The following is a description of a gene set: Human Gene Set: GOBP_CEREBRAL_CORTEX_GABAERGIC_INTERNEURON_DEVELOPMENT studied in species Homo sapiens The process whose specific outcome is the progression of a cerebral cortex GABAergic interneuron over time, from initial commitment to its fate, to the fully functional differentiated cell., and this is the list of marker genes: FEZF2, CNTN2, DRD1, RAC1, RAC3, DRD2, LHX6, ARX